The following is a description of a gene set: Human Gene Set: GOMF_PHOSPHORYLATION_DEPENDENT_PROTEIN_BINDING Binding to a protein upon phosphorylation of the target protein. species: Homo sapiens, and this is the list of marker genes: TOPBP1, VAV1, SOCS7, PLCG2, SOCS2, NBN, ANK2, LYN, PTPN6, YWHAG (NCBI Gene Id 96443)